Given this list of marker genes Bloc1s3, Hps1, Ticam1, Cd244a, Lyst, Il12b, Gas6, Irf1, Raet1d, Zbtb1, Il23a, H2-T23, Rasgrp1, Axl, Tyrobp, Stat5a, Jak2, Ulbp1, Il15ra, Bloc1s6, Tyk2, Flt3l, Stat5b, Il12a, Tox, Il15, Il18, Il21, here is a description of the gene set: Mouse Gene Set: GOBP_POSITIVE_REGULATION_OF_NATURAL_KILLER_CELL_ACTIVATION Any process that activates or increases the frequency, rate or extent of natural killer cell activation. studied in species Mus musculus